Given this list of marker genes WNT5A, NOG, EPHA2, EFNA1, WNT11, CRB2, PPP1R35, NCKAP1, GLI1, here is a description of the gene set: Human Gene Set: GOBP_NOTOCHORD_MORPHOGENESIS The process in which the anatomical structures of the notochord are generated and organized. The notochord is a mesoderm-derived structure located ventral of the developing nerve cord. In vertebrates, the notochord serves as a core around which other mesodermal cells form the vertebrae. In the most primitive chordates, which lack vertebrae, the notochord persists as a substitute for a vertebral column. species: Homo sapiens